Given this list of marker genes HAVCR2, CRTAM, NECTIN2, CEACAM1, CD226, TGFB1, IL12A, PVR, IL12B, CD160, here is a description of the gene set: studied in species Homo sapiens Human Gene Set: GOBP_REGULATION_OF_NATURAL_KILLER_CELL_MEDIATED_IMMUNE_RESPONSE_TO_TUMOR_CELL Any process that modulates the frequency, rate, or extent of natural killer cell mediated immune response to a tumor cell.